The following is a description of a gene set: Genes predicted to be targets of miRBase v22 microRNA mmu_miR_186_3p in miRDB v6.0 with MirTarget v4 prediction scores > 80 (high confidence targets). Mouse Gene Set: MIR_186_3P species: Mus musculus from publication Chen Y, Wang X (PMID 31504780), and this is the list of marker genes: Spaca7, Actr2, Zbtb5, Tnpo3, Asb3, Fam53c, C2cd5, Sec24c (NCBI Gene Id 72496), Tanc2, Ube2e2, Fam228b, Sfxn4, Brd8, Kif5c, Cmah, Kmt2c, Gmps, Gria4, Clec2i, Mrpl15, Nfia, Ddx17, Tbxas1, Paxbp1, Nipal4, Hunk, Pilra, Zfp800